The following is a description of a gene set: Pathway Definition from KEGG: BARF1 -> BCL2 -| (BAX,BAK1) -> CYCS == APAF1 -> CASP9 -> CASP3 EBV BARF1 to intrinsic apoptotic pathway. Pathway ID: N00478. Pathway type: Pathogen. Pathway class: nt06165 Epstein-Barr virus (EBV). Human Gene Set: KEGG_MEDICUS_PATHOGEN_EBV_BARF1_TO_INTRINSIC_APOPTOTIC_PATHWAY studied in species Homo sapiens, and this is the list of marker genes: BAX, CYCS, BAK1, APAF1 (NCBI Gene Id 317), CASP3 (NCBI Gene Id 836), CASP9, BCL2